Given this list of marker genes Tbx5, Gata4, Fgfr1, Wnt2, Ddx39b, Fgf2, Zfpm2, Fdps, Akap6, Hamp2, Parp2, Hey2 (NCBI Gene Id 30802), Gata6, Fgfr2, Ccnb1, Nrg1, Pin1, Pim1, Rbpj, Igf1, Cdk1, Sirt1, Fgf9, Tbx20, Tbx2, Notch1, Pin1rt1, Gli1, Edn1, Yap1, Ep300, Mtor, Tgfbr3 (transforming growth factor, beta receptor III), Wt1, Nr3c1, Prox1, Mapk1, Trip10, Bmp10, Mapk14, Tbx1, Adrb1, Erbb4, Ccnd2, Ccn4, Hamp, Mef2c, Ncam1, Acacb, Slc25a4, Bmpr1a, here is a description of the gene set: Any process that increases the rate or extent of heart growth. Heart growth is the increase in size or mass of the heart. Mouse Gene Set: GOBP_POSITIVE_REGULATION_OF_HEART_GROWTH species: Mus musculus